Given this list of marker genes NCKAP5-AS2, IL13RA1, DOCK4-AS1, TMEM144, FMNL3, LINC01909, LINC02918, ST8SIA4, NCK2, LILRB4, DAGLB, FERRY3, RAP1A, PAQR8, ENSG00000253214, LY86, TNFRSF10D, RNU7-71P, TGFBR1, GAL3ST4, SMAP2, FCGR1BP, ENSG00000258168, RPL34P19 (ribosomal protein L34 pseudogene 19), LINC01664, RN7SL297P, CREG1, MERTK, OLR1, SLCO2B1, ADAM28, STEAP1B, SNX30, GPN3, CSF1R, SRGAP2C, PALD1, LINC01094, ARHGAP27P1-BPTFP1-KPNA2P3, IFNGR1, RN7SL32P, LINC01768, TM6SF1, ACSM5 (NCBI Gene Id 54988), PDE4DIPP7, B3GNT5, PTAFR, ALOX5AP, SNRPD2P1, BHLHE41, DIP2B (NCBI Gene Id 57609), TLR6, MTCO1P11, NAA20, MIOS, TIGAR, CLEC19A, CAPZB, ZNRF2, SORL1, TLR4, PLA2G15, RNU7-29P, AZIN2, RHOQ-AS1, DOCK8, KCNK13 (potassium two pore domain channel subfamily K member 13), ENTPD1 (NCBI Gene Id 953), RTTN, SIGLEC10, SLC29A3, LINC02642, TNFSF18, LINC02953, MAML2, CH25H, APBB1IP, MAP4K4, LINC03070, SYNDIG1, FCGR3A, TREM2, LINC01645, EGR2, CX3CR1, LRRC37A6P, LRRC8C, TBC1D12, HMGA1P4, GAPLINC, EDNRB-AS1, SPP1, DPEP3, NPM1P10, LINC01141, HAVCR2, EGR3, GPR84, MGAT4A, RIN2, RPS10-NUDT3, SH3BGRL, MEF2A, GAB3, ST6GAL1, TMEM273, TMIGD3, EEIG2, NCK1-DT, ANKH, CSF2RA, LINC02798, DOCK4, FCGR2A, ENSG00000232884, MACORIS, RPL7AP42, LNCAROD, SIGLEC8, LRCH1, P2RY13, ITPR2, IL17RA, RHBDF2, SLC11A1 (NCBI Gene Id 6556), PDE4DIPP3, LINC01480, FPR1, LINC01235, LHFPL2, ABR, COX6CP17, GPR34, PTPRJ, GNB4, LRRK1, SLC9A9, SAMSN1, SRGAP2B (NCBI Gene Id 730266), IRAK2, ATG7 (NCBI Gene Id 105376952), PLXDC2, ARHGAP25, NCKAP5-AS1, LINC02712, ENSG00000249738, PANX1, PDK4, PDYN-AS1, GSN-AS1, SOCS6, CHORDC1P4, AP1B1, APPL2, ARHGAP12, RUBCNL, HPGDS, SFMBT2, LINC03002, ADRB2, FAR2, TRPM2, MROCKI, FCGR1A, MKNK1, TNF, TLR1, SUCNR1, SLC7A11-AS1, RABEP1, IL6R, GNG7, P2RY12, CEACAM21, NPL, STX7, LPAR5, LINC01736, ENSG00000249631, TLR7, FAM238A, LINC01375, IPCEF1, ITGAX, SLC2A5, VSIG4, here is a description of the gene set: Marker genes curated from the annotated cluster as represented in the Descartes Human Gene Expression During Development database. The gene expression program underlying the specification of human cell types is of fundamental interest. The study authors generated human cell atlases of gene expression and chromatin accessibility in fetal tissues. For gene expression, the study authors applied three-level combinatorial indexing to >110 samples representing 15 organs, ultimately profiling ~4 million single cells. The study authors leveraged the literature and other atlases to identify and annotate hundreds of cell types and subtypes, both within and across tissues. Our analyses focused on organ-specific specializations of broadly distributed cell types (such as blood, endothelial, and epithelial), sites of fetal erythropoiesis (which notably included the adrenal gland), and integration with mouse developmental atlases (such as conserved specification of blood cells). These data represent a rich resource for the exploration of in vivo human gene expression in diverse tissues and cell types. from publication Cao J, O'Day DR, Pliner HA, Kingsley PD, Deng M, Daza RM, Zager MA, Aldinger KA, Blecher-Gonen R, Zhang F, Spielmann M, Palis J, Doherty D, Steemers FJ, Glass IA, Trapnell C, Shendure J (PMID 33184181) Human Gene Set: DESCARTES_MAIN_FETAL_MICROGLIA species: Homo sapiens